The following is a description of a gene set: from publication Cui A, Huang T, Li S, Ma A, Pérez JL, Sander C, Keskin DB, Wu CJ, Fraenkel E, Hacohen N (PMID 38057668) Mouse Gene Set: CUI_LANGERHANS_G_CSF_RESPONSE_UP Genes positively differentially expressed in cell type: Langerhans upon treatment with cytokine: G-CSF in mouse lymph nodes in vivo. Cytokines mediate cell-cell communication in the immune system and represent important therapeutic targets. A myriad of studies have highlighted their central role in immune function, yet we lack a global view of the cellular responses of each immune cell type to each cytokine. To address this gap, the authors created the Immune Dictionary, a compendium of single-cell transcriptomic profiles of more than 17 immune cell types in response to each of 86 cytokines (>1,400 cytokine-cell type combinations) in mouse lymph nodes in vivo. A cytokine-centric view of the dictionary revealed that most cytokines induce highly cell-type-specific responses. For example, the inflammatory cytokine interleukin-1β induces distinct gene programmes in almost every cell type. A cell-type-centric view of the dictionary identified more than 66 cytokine-driven cellular polarization states across immune cell types, including previously uncharacterized states such as an interleukin-18-induced polyfunctional natural killer cell state. species: Mus musculus, and this is the list of marker genes: Zfp799, Bid, Tnfrsf10b, Armc1, Dnal4, Hs2st1, Mmp24os1, Nap1l4